Given this list of marker genes Chac2, Adsl, Chac1, Ggact, Pam, Asl, Ggct, here is a description of the gene set: species: Mus musculus Catalysis of the release of amides or amidines by the cleavage of a carbon-nitrogen bond or the reverse reaction with an amide or amidine as a substrate. Mouse Gene Set: GOMF_AMIDINE_LYASE_ACTIVITY